The following is a description of a gene set: Cytokines mediate cell-cell communication in the immune system and represent important therapeutic targets. A myriad of studies have highlighted their central role in immune function, yet we lack a global view of the cellular responses of each immune cell type to each cytokine. To address this gap, the authors created the Immune Dictionary, a compendium of single-cell transcriptomic profiles of more than 17 immune cell types in response to each of 86 cytokines (>1,400 cytokine-cell type combinations) in mouse lymph nodes in vivo. A cytokine-centric view of the dictionary revealed that most cytokines induce highly cell-type-specific responses. For example, the inflammatory cytokine interleukin-1β induces distinct gene programmes in almost every cell type. A cell-type-centric view of the dictionary identified more than 66 cytokine-driven cellular polarization states across immune cell types, including previously uncharacterized states such as an interleukin-18-induced polyfunctional natural killer cell state. from publication Cui A, Huang T, Li S, Ma A, Pérez JL, Sander C, Keskin DB, Wu CJ, Fraenkel E, Hacohen N (PMID 38057668) species: Mus musculus Mouse Gene Set: CUI_MONOCYTE_IL1A_RESPONSE_UP Genes positively differentially expressed in cell type: Monocyte upon treatment with cytokine: IL-1α in mouse lymph nodes in vivo., and this is the list of marker genes: Ccr1, Cltc (NCBI Gene Id 97762), C3ar1, Sec24d, Sys1, Hnrnpf, Il4ra, Ehd1, Dmkn, Ccr5 (NCBI Gene Id 235693), Clec4d, Cox17, Tes, Mt1, Ninj1, Ebna1bp2, Eps8, Mrpl52, Atp6v0a1, Rgl1, Slc7a11, Eif4a1, Bax, Rhou, Mafb, Ctsl, Thbs1, Fth1, Cndp2, Rab3il1, Tfec, Rab44, Lrrc59, Clec4n, Hnrnpab, Adam8, Lilrb4b, Plek, Tgm2, Slc11a1, Snx5, Sdc4, Il1rn (NCBI Gene Id 320052), Manf, Snx3, Irf2bp2, St7, Wnk1 (WNK lysine deficient protein kinase 1), Atp1a1, Siglece, Plaur, Ifi204 (NCBI Gene Id 15951), Mafg, F10, Cct3, Ctsb (cathepsin B), Spred1 (NCBI Gene Id 99293), Sod2, C5ar1, Cd33, Nme1 (NME/NM23 nucleoside diphosphate kinase 1), Rab20, Cd44, Ssr2, Igfbp6, Tarm1, Mrc1, Fcgr2b, Cd14, Snx2, Ccl2, Dnajb11, Socs3, Ppp1r14b, Vcan, Ltb4r1, Cd300lf, Zfp36l1, Morf4l2, Jaml, Ifitm2, Stx7, Fabp5, Tpm3, Ccl24 (NCBI Gene Id 56221), Vim, Slc39a14, Pkm, Rbbp6, Reep3, Ms4a6d, Hif1a, Bcl2a1d, N4bp1, Rbms1, Ctsz, Msr1, Adprh, BC031181, Ptpn1, Rbpj, Itgam, Bak1, Srgn, Riok3, Cd53, Lgmn, Cmklr1, Cish, Cfp (complement factor properdin), Glrx, Eif5a, Rbm3, Gsr, Fkbp5, Xbp1, Txnrd1 (NCBI Gene Id 50493), Cers2 (NCBI Gene Id 99568), Enah (ENAH actin regulator), Ffar2, Cd164, Tiam1, Dab2 (NCBI Gene Id 70555), Gda, Slfn2, Ccl12 (NCBI Gene Id 20293), Vapa, Srm, Calr, Acp2, Pilra, Tgfbi, Fcgr3, Cstb, Bcl2a1b, Dok2